Given this list of marker genes Hsd3b1, Hsd3b5, Cga, Hsd3b9 (NCBI Gene Id 100043461), Hsd3b3, Hsd3b6, Hsd3b4, Lhb, Cyp11b2, Hsd3b2, Hsd3b8, Cyp21a1 (NCBI Gene Id 13080), here is a description of the gene set: Mouse Gene Set: REACTOME_MINERALOCORTICOID_BIOSYNTHESIS Mineralocorticoid biosynthesis studied in species Mus musculus